The following is a description of a gene set: A macromolecular complex containing both protein and DNA molecules. studied in species Mus musculus Mouse Gene Set: GOCC_PROTEIN_DNA_COMPLEX, and this is the list of marker genes: Meaf6, H2ac24, Prpf19, H2al1n, H2ac6, H3c4, H2ac8, Hnrnpk, Nfe2l2, H1f9, H4c4, H1f8, H4c11, E2f6, Ruvbl2, Jund, Lef1, Shprh, Polr2h, Prim2, Gins2, H2ac11, Ep400, Orc3, Nfya, Pot1b, H2aj, H2bc12 (H2B clustered histone 12), Slc5a8, H2al2b, Nupr1, Nkx2-5, Gtf2b, Glyr1, H2ac23, Cdc45, Kat5, H2ac12, Cdc5lrt4 (NCBI Gene Id 668191), H2ab1, Mcm2, Tead4, Prm2, Ing3, H2ap, Polr2m, H2ac21, H2al1k, H2ab3, Ctnnb1, H2al1m (H2A histone family member L1M), Cdc5lrt9, Eya1, Myocd, Gins4, H2al1o, Sp1, H2bw2, Rpa3, H2bc14, Esr2, Kdm1b, Taf10, Helb, Actb, Tgm2, H2al1f, Ten1, H2az1, H4c8, Hoxa11 (NCBI Gene Id 15396), Prkdc, Hmga2, Mrgbp, Npm1, Noc2l, H2bc22, H2al1e, H2al3, Prim1, Vps72, Mcm3, Tcf7l2, Wdr18, H2al1b, Cdc5lrt10, Gata1, Tonsl, Mcm4, Pax2, Cdc5lrt5, H2ac15, H3c8, H4c9, Cdc5lrt8, H2ac13, Prm1, H1f0, Mcm7, H3c10, H4c6 (H4 clustered histone 6), H3c15, Rprd2, Ercc3, Max, H2az2, Cdc5lrt1, H4c18, H2bc26, H3f3c, Rpa1, H3f3b, Nfyc, Actr6, H2ac20, H1f6, H2ac7, Mcm5, Recql5, Brf2, Brd8, Morf4l2, Nfe2, Prm3, Rbpj, H3c2 (H3 clustered histone 2), Xrcc6, Tbx5, H2al1j, Ikzf1, H1f4, Trex1, H2bc27, Actl6a, H2ac25, H2bc3, H3c11, Morf4l1, H2ax, Tinf2, Cdc5lrt6, Pola1, Nfyb, H3f4, Terf1, H4c2, H1f2, Sox12, Ctc1, Kat6b, Pold1 (NCBI Gene Id 18971), Cdc5l, Pold2, Epc2, Suz12, Rag1, Brf1, Epc1, Med1, H3c14 (H3 clustered histone 14), Rad52 (NCBI Gene Id 19365), H3c13, Mcm6, Myzap, Xpa, Atf6b, H2ac4, Donson, H1f5, H1f1, Hhex, Fos, H2ac22, Macroh2a1, Hp1bp3, H2bc18, Gtf2a1, H4c3, H2ac19, Rpa2, Pold3, H3c7, Rprd1a, H3c3, Bcas2, Dmap1, Cenpa, Chd4, H2bc21, H3c6, Smarcal1, Ercc5, Yeats4, Rpap2, Stn1, Terf2ip, Myog, Zbtb17, H4c14 (H4 clustered histone 14), Gins1, Top1, H2bc9, Trrap, H4c1, H3f3a, H2bc1, H2al2a, Acd, Pot1a, Cdc5lrt7, Ep300, Mphosph8, St18, Mbtd1, Jup, Kdm5a, H4c16, Plrg1, Znhit1, Tcf3, Kat6a, Terb1, Kcnip3, Pold4, Rprd1b, Xrcc5 (NCBI Gene Id 98297), H1f3, Parp1 (poly (ADP-ribose) polymerase family, member 1), Tnp1, H3c1, Macroh2a2, H2ab2, Ddit3, Tnp2, Rag2, H2ac1, Irf4, H4c17, Terf2, Sp3, Slf1, H4c12, Ruvbl1, Gtf2h3, Pola2, H2ac10, Sphk2, Gins3, H2bl1